The following is a description of a gene set: Genes predicted to be targets of miRBase v22 microRNA hsa-miR-6861-3p in miRDB v6.0 with MirTarget v4 prediction scores > 80 (high confidence targets). studied in species Homo sapiens from publication Chen Y, Wang X (PMID 31504780) Human Gene Set: MIR6861_3P, and this is the list of marker genes: COL13A1, HNRNPA0, ATRN, KIAA0040, IKZF2, NDST1, LRCH2, DMBX1, PPP1R8, PIGM, BTG2, CAMK2G, ROR2, DPY30, C9orf152, RTF2, CNOT2, TTC19, LYPD8, KLC4, ITGB1BP1 (integrin subunit beta 1 binding protein 1), MARCHF2, NKAIN3, TRAF3, MDP1, ABHD3, ETF1, SYNJ2, ASB7, THOC1, CBFA2T3, GABRA1, ACSS1, HECTD4 (NCBI Gene Id 283450), ZNF211, LYST, TMPRSS2, GRIK2, SHISA7, SVOP, MEST, TBL1XR1, SACM1L, TMEM50A, TYRP1, SUV39H1, KCNB1, PHLDB1, GOLPH3